Given this list of marker genes CD44, SMIM30, PITX1 (NCBI Gene Id 5307), ST3GAL5 (NCBI Gene Id 8869), PFDN5 (prefoldin subunit 5), GATD3, HIF1A, ADAM8 (NCBI Gene Id 101), PLD2, SSB, SNAP23, ICA1, TWIST2, PRDX2, LGALS3, MBNL1, SNTA1, BMPR1B, S100A4, ICAM1, GZMB, IL1RL1, ELK4, IL4 (NCBI Gene Id 3565), LZTFL1, TLR1, SELENOM, DYNLL2, CHIA (NCBI Gene Id 27159), TPI1, MDFIC, BMP7, ID2, RPS27L, SOCS3, ZRSR2, POLR2D, AIFM1, SLAMF1, CHST2, BVES, MAP6, SMPDL3A, THUMPD3, ZFP36L1, CENATAC, KSR1, CIR1, CTLA4, RBM3, GZMK, VPS54, RNF208, INPPL1, PPP3CC, PLA2G10, GBP4, FRMD4B, MAIP1, SLC39A8, NDUFA4, CDK2AP1, METRNL (NCBI Gene Id 653506), RHBDL3, RYK, MST1, SLC38A5, HEMGN, ATP5IF1, PRC1, BCL2A1, TMEM140, KHDRBS1, RGS1, KLRG1, CASP1 (caspase 1), TMEM258, DTL, TK1, RILPL2, BSCL2, GFI1, CYP4B1, IGHG1, TXNDC17, GADD45G, OLA1, GNPDA2, CXCR6, SLC22A17, ECI2, STRC, LDAF1, SNRNP70, MECP2, ING2, ZNF112, GLRX, SCGB3A1, IL15RA (NCBI Gene Id 3601), SOCS2, NUMBL, CCR5, NEAT1, ZAN, AIM2, SYNC, F2R, BCAP29, ST6GALNAC1, TFRC, CMPK1, BOC, TBX21, TMEM82, BHLHE40, IL12RB1, CCR2, GBP2, AQP9, PMEPA1, CST7, TASOR2 (NCBI Gene Id 54906), IL18RAP (interleukin 18 receptor accessory protein), NAA15 (N-alpha-acetyltransferase 15, NatA auxiliary subunit), SIN3B, TASP1 (NCBI Gene Id 55617), IFNG, PPP2R3C, FAM241B, FGL2, SEC61G, RNASE4, GATA3 (NCBI Gene Id 84828), HNRNPA1, SERINC3, CA1, SLC4A5, MSANTD4, CDC37L1, RPL26, TAF9, TXN, HLA-G, S100A1, CIBAR1, SDF4, MRPS17, LPXN, IFITM2, PSMC4, CASP4, CDA (NCBI Gene Id 978), SERHL2, S1PR5, DHPS, CHMP2A, SCN11A, CDK6 (cyclin dependent kinase 6), HMGB3, SAT1, FLYWCH2, PTAFR, CTTN (cortactin), RB1, PSMB2, ABCB1, GNG10, OTUB2, GPM6B, CSF1, ISCA2, CTSW, EOMES, RIPK3, ATG10, ARMCX5, WSB1, SLC4A7, CNR1, CISH, NOTCH4, KIF22 (kinesin family member 22), EFCAB7, SLC10A2, TTC16, TTC39B, GSTT2 (glutathione S-transferase theta 2 (gene/pseudogene)), NCMAP, ATP5F1C, ABCG1, ZWILCH, SSTR1, SON, KAT2B, CLCNKB, EPDR1 (NCBI Gene Id 96010), HMGB1, MBD3L1, GLOD4, here is a description of the gene set: studied in species Homo sapiens Genes down-regulated in comparison of T effector cells from uninfected mice versus T effector cells from mice infected with S. mansoni. from publication Layland LE, Mages J, Loddenkemper C, Hoerauf A, Wagner H, Lang R, da Costa CU (PMID 20007528) Although several markers have been associated with the characterization of regulatory T cells (Treg) and their function, no studies have investigated the dynamics of their phenotype during infection. Since the necessity of Treg to control immunopathology has been demonstrated, we used the chronic helminth infection model S. mansoni to address the impact on the Treg gene repertoire. Before gene expression profiling we first chose to study the localization and antigen-specific suppressive nature of classically defined Treg during infection. Presence of Foxp3+ cells were found especially in the periphery of granulomas and isolated CD4+CD25hiFoxp3+ Treg from infected mice blocked IFN-gamma and IL-10 cytokine secretion from infected CD4+CD25- effector T cells (Teff). Furthermore the gene expression patterns of Treg and Teff showed that in total genes were significantly regulated during chronic schistosomiasis. Upon k-means clustering we identified genes exclusively regulated in all four populations including Foxp3, CD103, GITR, OX40 and CTLA-4: classical Treg markers. During infection however, several non-classical genes were up-regulated solely within the Treg population such as Slpi, Gzmb, Mt1, Fabp5, Nfil3, Socs2, Gpr177 and Klrg1. Using RT-PCR we confirmed aspects of the microarray data and in addition showed that the expression profile of Treg from S. mansoni-infected mice is simultaneously unique and comparative with Treg derived from other infections Human Gene Set: GSE17580_UNINFECTED_VS_S_MANSONI_INF_TEFF_DN